Given this list of marker genes ALOX5, ALOX12, here is a description of the gene set: The polyunsaturated fatty acid (PUFA) ω-3 cis-7,10,13,16,19-docosapentaenoic acid (DPAn-3) is an intermediate in the biosynthesis of docosahexaenoic acid (DHA) from eicosapentaenoic acid (EPA) and is also a precursor for the production of novel bioactive mediators.The proposed biosynthesis of maresins derived from DPAn-3 is described here. 12-lipoxygenase oxygenates DPAn-3 to its 14(S) hydroperoxy epimer from which maresins are formed via a combination of oxygenation, reduction and hydrolysis reactions. The products of the ω-3 isomer were characterised based on docosahexaenoic acid (DHA)-derived maresins and were demonstrated to have similar potent systemic anti-inflammatory and tissue protective actions as DHA-derived specialised proresolving mediators (SPMs). The same biosynthetic route as DHA-derived SPMs is probably how DPAn-3 products are also formed. part of: Biosynthesis of DPAn-3 SPMs Reactome Pathway: Biosynthesis of DPAn-3-derived maresins studied in species Homo sapiens